Given this list of marker genes FOXRED2, DAD1, DDX18, CACNG7, PAGR1, ECM2 (NCBI Gene Id 1842), CXXC1P1, FUS, FAAP100, F13A1, CTTNBP2, CENPF, C2orf15, CDS1, DCP2, C3orf70, ADAMTSL3, BLCAP, ALKBH7, TMA7, CHD9, CYP7B1, C17orf75, FKBP7, CCDC152, DNASE1L3, TMEM263, DMBX1, BTN1A1, CALCA, FAM47A, CEACAM1, C12orf60, BPIFB6, CYBC1, LBX1-AS1, CSNK1D, FBXO46, FAM111B, ACOT6, DYNC1I1, CTAG2, CR2, GABRR3, CRBN, EEF1D, MTRES1, CAMSAP2, ETNK2 (NCBI Gene Id 55224), CHUK (component of inhibitor of nuclear factor kappa B kinase complex), DIO1, DPYS, LRRC8C-DT, DDAH2, DNAH12 (NCBI Gene Id 8679), THEMIS2, ZBTB7C-AS2, CHRNA1, ARHGAP21, CXCL14, CGGBP1, ALX1, AKAP9, FCSK, CETN2, ECM1, AP4B1, CCDC180 (NCBI Gene Id 100499483), ARPIN, SUCO (NCBI Gene Id 51430), CA5BP1, CHRNG, BCL11A, ARHGEF16, SMG8, CTSV, BTNL8, C2CD2, CD46, FRRS1L (NCBI Gene Id 23732), CUBN, ASB12, EXOC7, ZNF736, CELF6, DACT1, MFSD12, DUS1L, GABARAPL3, EML3, BTAF1, COMMD7, CA8, CYMP, LINC02915, PAXBP1-AS1, CREB3L4, CLTCL1, NDNF (neuron derived neurotrophic factor), CHRNB2, ATM, FKRP, ACSL1, GASK1B, GAS6-DT, FBXO3, ARHGAP28, ANAPC7, FITM1, GCAT, LINC03040, C11orf21, COPG2 (COPI coat complex subunit gamma 2), CALML4, OGFOD3, C4orf36, AK9, MCUB, CHKA, CABLES1, FTO, LINC00587, C1orf122, ATAD3A, ANKRD45, TBC1D32, CDC26, ALK, FAM86C1P, CITED4, ALPK1 (NCBI Gene Id 80216), ANO8, CDK5RAP2, CLCN3, ECI2, CNNM4, DNTTIP1, C2CD3, LINC02880, BBS1, CD7, BBOX1, CYBB, ACTR3B, ERP29, ADCY7, TLCD3B, DHX58 (DExH-box helicase 58), ETS1, ACAT2, EVX1, BCDIN3D, CNGA3, CHL1, ATXN1L, CHCHD7, AGXT, FUNDC1, CCS, DDX11L2, EFCAB10, ARIH1, DCHS2, CPNE3, FAM181B, ASB3, BCOR, C1R, C9orf40, DUS4L, COL10A1, CCDC110, INTS6L, ATRN, C8orf17, FAM9A, DEPTOR, DDT, FRAT2, CGNL1, CYTIP, DNAJC28, FBH1, ANO10, CHRNA2, CMTM5, DCAKD, ANAPC15, ALDH16A1, BAALC-AS2, COIL, FLYWCH2, BOLA3, here is a description of the gene set: studied in species Homo sapiens Human Gene Set: GSE15659_NAIVE_VS_PTPRC_NEG_CD4_TCELL_UP Gene expression profiles of subsets of CD4+ T cells according to their expression of FoxP3 and CD45RA were compared. FoxP3 is a key transcription factor for the development and function of natural CD4+ regulatory T cells (Tregs). Here we show that human FoxP3+CD4+ T cells are composed of three phenotypically and functionally distinct subpopulations: CD45RA+FoxP3low resting Tregs (rTregs) and CD45RA-FoxP3high activated Tregs (aTregs), both of which are suppressive in vitro, and cytokine-secreting CD45RA-FoxP3low non-suppressive T cells. The proportion of the three subpopulations characteristically altered in cord blood, aged individuals, and patients with immunological diseases. Terminally differentiated aTregs rapidly die while rTregs proliferate and convert into aTregs in vitro and in vivo as shown by the transfer of rTregs into NOD-scid-common gamma-chain-knockout mice and by TCR sequence-based T cell clonotype tracing in peripheral blood of normal individuals. Taken together, the dissection of FoxP3+ cells into subsets enables one to analyze Treg differentiation dynamics and interactions in normal and disease states, and to control immune responses through manipulating particular FoxP3+ subpopulations. Genes up-regulated in comparison of naive CD4 T cells versus PTPRC+ CD4 T cells. from publication Miyara M, Yoshioka Y, Kitoh A, Shima T, Wing K, Niwa A, Parizot C, Taflin C, Heike T, Valeyre D, Mathian A, Nakahata T, Yamaguchi T, Nomura T, Ono M, Amoura Z, Gorochov G, Sakaguchi S (PMID 19464196)